The following is a description of a gene set: species: Mus musculus The chemical reactions and pathways involving retinoic acid, one of the three components that makes up vitamin A. Mouse Gene Set: GOBP_RETINOIC_ACID_METABOLIC_PROCESS, and this is the list of marker genes: Cyp3a44, Crabp2 (cellular retinoic acid binding protein II), Cyp26c1, Rdh16, Adh6a, Aldh1a3, Adh6b, Rbp1, Rdh1, Aldh1a2, Cyp3a41b, Cyp2w1, Adh7, Cyp26a1, Prmt3, Adh1, Rdh19, Cyp2s1, Aldh1a7, Cyp3a11, Klf9, Strap, Rdh9, Dhrs9, Rdh16f2, Bco2, Cyp26b1, Akr1c18, Cyp1a1, Cyp3a41a, Aldh8a1, Aldh1a1, Rdh10, Lcn5, Cyp3a16, Sp1, Cyp2c55